Given this list of marker genes Crmp1, Dpysl2, Dpyd, Dpys, Aldh6a1, Dpysl3, Dpysl4, Dpysl5, here is a description of the gene set: Mouse Gene Set: GOBP_PYRIMIDINE_NUCLEOBASE_CATABOLIC_PROCESS studied in species Mus musculus The chemical reactions and pathways resulting in the breakdown of pyrimidine nucleobases, 1,3-diazine, organic nitrogenous bases.